Given this list of marker genes Sptbn4, Tac1, Trpv1, Sri, Npff, Fkbp1b, Rnls, Gjd3, Adra1a, Pln, Spx, Chrm3, Tnf, Agtr2, Pik3r1, Uts2, here is a description of the gene set: species: Mus musculus Any process that stops, prevents or reduces the frequency or rate of heart contraction. Mouse Gene Set: GOBP_NEGATIVE_REGULATION_OF_HEART_RATE